Given this list of marker genes SMC4, BSG, PPA1, MOGS, C11orf71, VNN2, SUMO1, NKG7, ICAM2, SF3B5, CTC1, NDUFB2, PPOX, CEBPD, FAS, NRDC (NCBI Gene Id 4898), CHP1, CIAO1, INTS7, IFT25, RASGRP1, ADA, LCP2, GTF2E2, PLD3, SCAMP2, ADRM1, SPATS2, MYDGF, PEF1, ITCH, PPIE, RNF126P1, CXCR3, IDH2, ARPC1B, HTATIP2, ITFG1, UGT2B17, PRKCD, LTC4S, NDUFA4, TRAM1, FKBP11 (FKBP prolyl isomerase 11), KLF8, UBFD1, UBA1, RETSAT, OLA1, RAB8A, GLRX2, FLAD1, BAIAP3, YWHAH, TMED9, PRDX3, SRI, ITGB7 (NCBI Gene Id 3695), ABHD3, G6PC3, JPT1, SNRPG, ORMDL2, VTI1B, FAM114A2, KPNA2, NFE2L3, LRRC42, HMGB2, MSL1, NDUFS8, SLC25A1, SEC61B, ALG5, DYRK4, RANGAP1, BSCL2 (NCBI Gene Id 84753), CPE, THAP4, GOLPH3L, MLX, GNG7, ALG8, CTSA, CASP7, DAP, TRAF3IP3, TOP6BL, NDUFB3, SSR1, PSMD8, PSMB2, PPP1R7, RWDD2A (RWD domain containing 2A), SLC25A5, H2BC12L, SLC7A7, DOK2, BAK1, ARL2, ATP5MC3, PSME2, GLRX, CAPRIN1, PITPNM3, AKT3, ACBD3, DNAAF5, ATF6, PSMD14, TM9SF1, FLNA, G0S2, SEC14L1 (SEC14 like lipid binding 1), ISOC1, MCUR1, TMED10, PSMA4, LILRB4, NOP10, DNAJC3, EIF3J, NCOR1, TLE1, BCKDHA, COX7B, AARS1, PSMA3, FIS1, ATRAID, FDX1, FLOT1, NIF3L1, UFC1, BET1, RAD17, GPKOW, ASNS, MRPS15, RNF31, MAGEH1 (NCBI Gene Id 94692), NOD2, ITM2C, MAGED2, AP2S1, OAS2, RUVBL1, THOC7, SPCS3, HNRNPC, RHOB, SERBP1, SMAP1 (NCBI Gene Id 648324), ALDOB, USP18, ZNHIT1, TDP1, PABPC4, TMEM135, ELAC2 (elaC ribonuclease Z 2), TAP1, TXN, UBE2L3, ZFAND6, UQCRQ, EXOSC9, ACAA2, NDUFA5, ZNF767P, NUDT21, TST, SNRPA, MRPL58 (NCBI Gene Id 3396), STOML2, ICMT, PPP1R2, MYL12A, PSMB5, ZNF706, SELPLG, SCAMP3, ATP5F1B, HIKESHI, TMEM230, AKR1B1, FDXR (ferredoxin reductase), PREB, UBXN6, UCHL3 (NCBI Gene Id 7347), WFS1, DSTN, PSMB7, MT1E, LRRC41, SMCHD1, FAM136A, AP3B1, OGT, here is a description of the gene set: Human Gene Set: GSE12845_IGD_NEG_BLOOD_VS_NAIVE_TONSIL_BCELL_UP Genes up-regulated in comparison of IgD- peripheral blood B cells versus dark zone germinal center B cells. B cells from human tonsil and blood were sorted using flow cytometry. The human samples were processed immediately ex-vivo using markers for known B cell subsets. from publication Longo NS, Lugar PL, Yavuz S, Zhang W, Krijger PH, Russ DE, Jima DD, Dave SS, Grammer AC, Lipsky PE (PMID 19023113) studied in species Homo sapiens